The following is a description of a gene set: The biological process whose specific outcome is the progression of a chorion from an initial condition to its mature state. This process begins with the formation of the structure and ends with the mature structure. The chorion is an extraembryonic membrane. Human Gene Set: GOBP_CHORION_DEVELOPMENT species: Homo sapiens, and this is the list of marker genes: ASCL2, DNMT3L, HTRA1, MAP3K4, FZD5, TMED2 (transmembrane p24 trafficking protein 2), DNAJB6, PAXIP1, E2F8, E2F7